The following is a description of a gene set: Human Gene Set: REACTOME_HYALURONAN_UPTAKE_AND_DEGRADATION studied in species Homo sapiens Hyaluronan uptake and degradation, and this is the list of marker genes: CD44, HEXB, HYAL2, HYAL1, LYVE1, CHP1, STAB2, SLC9A1, HYAL3, GUSB, HEXA, HMMR